The following is a description of a gene set: studied in species Mus musculus Enables the transfer of iron (Fe) ions from one side of a membrane to the other. Mouse Gene Set: GOMF_IRON_ION_TRANSMEMBRANE_TRANSPORTER_ACTIVITY, and this is the list of marker genes: Slc39a14, Tfrc, Slc40a1, Mcoln2, Mcoln1, Slc11a2, Slc11a1, Slc25a37, Mmgt1, Hamp2, Slc25a28, Hamp